Given this list of marker genes GRN (NCBI Gene Id 2896), TIA1, MT-TS2, MT-TW, PRNP, ATXN8OS, RNF216, MT-CO2, MT-TH, APOE, MT-TT, CHMP2B, PLA2G6, EIF2B1, ATXN2 (NCBI Gene Id 8095), MT-CO1, TIMM8A, MT-ND5, SNCAIP, MT-TL1, GBA1, NOTCH3, VPS13A, TBP, MT-ND4, NR4A2, MT-TQ, VCP, MT-CO3 (mitochondrially encoded cytochrome c oxidase III), TYROBP, MT-TF, TREM2, MT-ND6, TBK1, MMACHC, MAPT, SQSTM1, TMEM106B, NF2, PSEN1 (presenilin 1), ADH1C, HTT, ATP7B, ATXN3, MT-ND1, HLA-DQB1, JPH3, DCTN1, AARS1, PNPLA6, here is a description of the gene set: studied in species Homo sapiens Human Gene Set: HP_PERSONALITY_CHANGES Personality changes An abnormal shift in patterns of thinking, acting, or feeling.